The following is a description of a gene set: from publication Reichert N, Wurster S, Ulrich T, Schmitt K, Hauser S, Probst L, Götz R, Ceteci F, Moll R, Rapp U, Gaubatz S (PMID 20404087) species: Mus musculus The retinoblastoma tumor suppressor protein (pRB) and related p107 and p130 pocket proteins function together with the E2F transcription factors to repress gene expression during the cell cycle and development. Recent biochemical studies have identified the multisubunit DREAM pocket protein complexes in Drosophila melanogaster and Caenorhabditis elegans in regulating developmental gene repression. Although a conserved DREAM complex has also been identified in mammalian cells, its physiological function in vivo has not been determined. Here we addressed this question by targeting Lin9, a conserved core subunit of DREAM. We found that LIN9 is essential for early embryonic development and for viability of adult mice. Loss of Lin9 abolishes proliferation and leads to multiple defects in mitosis and cytokinesis because of its requirement for the expression of a large set of mitotic genes, such as Plk1, Aurora A, and Kif20a. While Lin9 heterozygous mice are healthy and normal, they are more susceptible to lung tumorigenesis induced by oncogenic c-Raf than wild-type mice. Together these experiments provide the first direct genetic evidence for the role of LIN9 in development and mitotic gene regulation and they suggest that it may function as a haploinsufficient tumor suppressor. Human Gene Set: REICHERT_MITOSIS_LIN9_TARGETS Genes with known mitosis function that were down-regulated in MEF cells (embryonic fibroblast) upon knockout of LIN9., and this is the list of marker genes: CENPA, CCNB1, HMMR, HMGB2, PLK1, CALD1, MKI67, AURKA, KIF20A, KNL1, CENPF, CDK11B, MYO6, CENPE, ASPM, NUSAP1, TOP2A, CDCA2, LMLN, KIF23, NCAPD2, CEP55, VCPIP1, ANAPC1, CCNF, KIF2C, FBXO5